Given this list of marker genes Tmtc1, Pigb, Fkrp, Large2, Tmem260, B4gat1, Pomt1, Crppa, Tmtc3, Tmtc2, Rxylt1, Dolk, Pomgnt2, Large1, Pomt2, Tmtc4, Pomgnt1, Nus1, Fktn, Dpm1, here is a description of the gene set: species: Mus musculus The covalent attachment of a mannose residue to a substrate molecule. Mouse Gene Set: GOBP_MANNOSYLATION